The following is a description of a gene set: Human Gene Set: GOMF_ADENYL_NUCLEOTIDE_EXCHANGE_FACTOR_ACTIVITY studied in species Homo sapiens Binds to and stimulates the hydrolysis and exchange of adenyl nucleotides by other proteins., and this is the list of marker genes: GRPEL2, BAG2, HSPH1, CCAR2, GRPEL1, HSPBP1, BAG5, HSPA4L, PFN1, BAG4, HSPA4, BAG3, HYOU1, BAG1, SIL1